Given this list of marker genes BLOC1S5, CD63, RAB38, BLOC1S6, RAB32 (RAB32, member RAS oncogene family), ANKRD27, AP3D1, AP1M1, AP1G1, BLOC1S3, here is a description of the gene set: species: Homo sapiens Human Gene Set: GOBP_PIGMENT_GRANULE_MATURATION Steps required to form a membrane-bounded organelle into a pigment granule containing pigment. Maturation is a developmental process, independent of morphogenetic (shape) change, that is required for a cell or structure to attain its fully functional state.